Given this list of marker genes CLDND1, RNF44, ZNF707, THADA, ITPRIPL2, COASY, CMSS1, RSRC1, FBXO6, ANG, NDUFV2, AP3B1, COX17, AVPI1, CANT1, OSTM1, AEBP2, MGA, PSMB4, EIF3K, NEDD4L, STAMBPL1, CSNK1E, AK2, RUVBL2, UBAC2, KHDRBS1, TTC5, OPA1, OSBPL5, PGGT1B, ZKSCAN3, NDUFS3, P2RX4, TUG1, GSTO1, ADAM9, MSRB2 (NCBI Gene Id 51648), JUNB, NDUFS4, TPCN2, CAPG, ASS1, IER5, CDK13 (cyclin dependent kinase 13), GRK5, FOXN2, SEPHS2, DHX9, ZNF319, PRKCSH, DDX3X, TRAF3IP3, DDX28, CAPNS1, MRPS25, BIN1, THEMIS, FDXR, DNAH8, CCDC102A, WDR47, PHF2, CPNE1, MDP1, PRPF6, ACP3, FAM204A, VCPKMT, DNLZ, SMAD7 (SMAD family member 7), MRPL42, FEM1C, GOSR2, TXNDC17, HACD3, MPHOSPH10, PSMA4, VIPR1, BBS9, ZMIZ1, ARID3B, DCUN1D2, MNT, CNBP, WDR89, API5, SLC30A6, ALKBH3, C3, GALNS, IFT27, ZC3H7A, IGFLR1, ZNF606, CCDC43, GNPDA2, EXOSC4, IRF2BPL (interferon regulatory factor 2 binding protein like), TOR3A, TARS1, C19orf25, MED28, OLFM1 (NCBI Gene Id 22825), EGR1, SURF1, SIRT2, WDR77, FKBP4, SNTB2, RGS1, KDM2B, PHF23, ECE1, LYPLA1, EXOC1, ZNF771, EFL1, CLDN12, ADGRL3, IMP4, AAMDC, ENOX2, S1PR1, CALHM2, ABHD12 (NCBI Gene Id 26090), MRPL36, NHLRC3, LYPD6B, FBXO25, ZFP36, ZBTB24, PLSCR1, CPEB2, BCL6, TBC1D14, FAM53A, NDUFS7, PHF6, GM2A, ZHX2, KMT2D, STK39, ORC4, STX16, NMT2, SLMAP, LSM14B, TRIM13, TMEM168, TOGARAM1, COG3, VSIG10, ZFP90, MBTPS2, TRIM45, OSBPL7, ZMYM4, HNRNPH1, CSNK1D, TMEM120A, FAM120B, GLB1, TREML2 (triggering receptor expressed on myeloid cells like 2), MECR, HNRNPU, TRIT1, NOP56, MYO9B, ALKBH1, KCNJ8, KDM5B, CCDC117, TNIP2, ZDHHC4, NKAPD1, MFSD1, PACRGL, PIP4P2, ZC3H13, DUSP7, SPO11, ACYP1, NCBP2AS2, DDOST, PHF21A, ZNF518A, OBI1, ARPC5L, TCF25, EXT2, ICMT, SIRT7, MAP3K3, TRIM14, ITGAX, GADL1, POGLUT2, BBS12, here is a description of the gene set: Human Gene Set: GSE27786_NKTCELL_VS_ERYTHROBLAST_UP Each fraction of mouse hematopoietic cells was purified by cell sorting from bone marrow of 8-week-old C57BL/6 mice, and its gene expression was analyzed. Genes up-regulated in comparison of NKT cells versus erythroblasts. studied in species Homo sapiens from publication Konuma T, Nakamura S, Miyagi S, Negishi M, Chiba T, Oguro H, Yuan J, Mochizuki-Kashio M, Ichikawa H, Miyoshi H, Vidal M, Iwama A (PMID 21540074)